The following is a description of a gene set: Mouse Gene Set: GOMF_THIOLESTER_HYDROLASE_ACTIVITY species: Mus musculus Catalysis of the reaction: RCO-SR' + H2O = RCOOH + HSR'. This reaction is the hydrolysis of a thiolester bond, an ester formed from a carboxylic acid and a thiol (i.e., RCO-SR'), such as that found in acetyl-coenzyme A., and this is the list of marker genes: Ptprt, Mblac2, Esd, Hnf4a, Acot2, Fasn, Them5, Abhd13, Abcd3, Hibch, Acsbg2, Acot10, Lypla1, Acot8, Acot4, Abcd2, Abhd10, Acot9, Lypla2, Abhd17a, Aldh6a1, Abhd12, Acot5, Abcd1, Acot6, Acot1, Acnat2, Desi2, Acot12, Acnat1, Cpt1c, Lyplal1, Cln5, Acot7, Acot3, Acaa2, Abhd17b, Olah, Haghl, Acot11, Pnkd, Acot13, Them4, Desi1, Abhd17c, Pla2g6, Hagh, Ppt2, Ppt1, Them7, Baat